The following is a description of a gene set: Human Gene Set: SAFFORD_T_LYMPHOCYTE_ANERGY from publication Safford M, Collins S, Lutz MA, Allen A, Huang CT, Kowalski J, Blackford A, Horton MR, Drake C, Schwartz RH, Powell JD (PMID 15834410) studied in species Mus musculus T cell receptor engagement in the absence of proper accessory signals leads to T cell anergy. E3 ligases are involved in maintaining the anergic state. However, the specific molecules responsible for the induction of anergy have yet to be elucidated. Using microarray analysis we have identified here early growth response gene 2 (Egr-2) and Egr-3 as key negative regulators of T cell activation. Overexpression of Egr2 and Egr3 was associated with an increase in the E3 ubiquitin ligase Cbl-b and inhibition of T cell activation. Conversely, T cells from Egr3(-/-) mice had lower expression of Cbl-b and were resistant to in vivo peptide-induced tolerance. These data support the idea that Egr-2 and Egr-3 are involved in promoting a T cell receptor-induced negative regulatory genetic program. Genes up-regulated in anergic mouse T helper cells (A.E7), versus non-anergic stimulated controls, and this is the list of marker genes: LAG3, MICB, RNF19A, ADORA2A, ISYNA1, ANKRD28, CCL3, KCNQ5, IRF4, MYH14, ADORA2B, TINAG, PFKP, ACTN4, PLA2G10, ARFIP1, HSPA1A, DDR1, JARID2, HSD17B6, KIFC3, GADD45B, HSPA4L, GCH1, FOXP1, KCNK5, TEKT2 (NCBI Gene Id 27285), ETV6, TP53RK, TNFSF9, GGA2, FURIN, MYL7, ZFP36L1, RCBTB1, MYO1C (NCBI Gene Id 4641), DUSP6, NDRG1, GABRA4, JUP, KIF15, NR4A2, HIF1AN, ZNF629, AGT (angiotensinogen), MYO1E, TAGAP, IER3, EGR2, TNFSF11, FBXO34, SOCS4, F2R, BNIP3, CD40LG, NOTCH1, SRGN, MMD, DLG2, STX11, MARCHF2, MPZL2, ING4, DTNA (dystrobrevin alpha), SFRP4, JAK3, S100A5, HEBP2, CCL1, TNFRSF4, CASP4, CLEC4E, FYN, NFATC1, CTSE, NOCT, NR4A3, OAZ3, LPAR4, LRRC3, CDC14A, SLC29A3, KCNJ11, HLF, ADGRE5, ANP32A, ANGPTL2, TNFRSF19, CSF1